The following is a description of a gene set: In this study gene expression of human blood classical monocytes (CD14++CD16-), CD16 positive monocytes (consisting of non-classical CD14+16++ and intermediate CD14++CD16+ monocytes) and CD1c+ CD19- dendritic cells from healthy subjects were investigated. species: Homo sapiens from publication Frankenberger M, Hofer TP, Marei A, Dayyani F, Schewe S, Strasser C, Aldraihim A, Stanzel F, Lang R, Hoffmann R, Prazeres da Costa O, Buch T, Ziegler-Heitbrock L (PMID 22531920) Genes down-regulated in CD16- monocytes versus dendritic cells. Human Gene Set: GSE34515_CD16_NEG_MONOCYTE_VS_DC_DN, and this is the list of marker genes: CRK, LAIR1, CDKL4, PRR5L, ADGRE5, MAP1LC3A, SEPTIN6, CSNK2B, MRPS34, BRD2, MRPL22, PRPSAP1, CREG1, ADAT1, ENPP4, CSRP3, ARMC6, RAB5C, RNF167, CPNE1, TRAPPC2L, DNMT3B, ATP8A2, PHF20, ELMOD2, GCAT, PHPT1, SERPINB8, SPPL3, EVI2B, EIF3G, RPL19, GPR108, CNR2, NEDD4L, DCAF1, IFT46, KLHL22, PI4KB, ACVR1B, SF3A3, ZNRF1, SPNS1 (SPNS lysolipid transporter 1, lysophospholipid), NSA2, RAPGEF1, NSUN2, NGDN (NCBI Gene Id 338007), STPG4, FAM219B, SLC6A6, PHB2, TTC36, GRAMD2B, RDH5, OMA1, RTCB, DHRS13, RRP15, SNAPC2, ZNF32, RAP2B, IRF2BP1, ELOVL6, SLC7A5, MRPS18B, RPAIN, PTK2B, ARFRP1, PPP5C, TNFRSF1A, CYB5B, UBASH3A, METTL22, MSN, ENTPD5, ELP1, GJA1, NDUFB2, GUSB, NOB1, SELENOS, C10orf90, SETX, PFDN5, CLIC4, IFI35, MTFR1L, GSTCD, FOXG1, PECAM1, HDAC3, DIABLO, MACROH2A1 (macroH2A.1 histone), ARHGAP45, SCNM1, CASP8, CCDC82, BSDC1 (NCBI Gene Id 55108), NTPCR, CRYL1 (NCBI Gene Id 51084), USP31, CNOT4, PPM1F, SESN3, TAF8, NSUN5, CERS6, ENPP6, UBD, SSBP4, SCAMP2, SLC29A1, HINT2, PSME1, STIM2, ARL2, BORA, EEF1AKMT1, COPZ1, RACK1, AKR7A2, RFX1, ABI3, BUD31, IFI30, ERCC5, KAT14, UGCG, IL12RB1, SNHG3, DALRD3, LAP3, CXCR6, SLC22A5, ZXDC, LIPA, BRK1, SHMT2, UBL4A, MAMDC4, SURF1, PSME3IP1, UROS, FCGR2A, QRICH1, TMCC2, MAX, CISD3, PLEKHF1, NDUFS5, YIF1B, GALNT12, WARS1, CA2, RILPL1, QTRT2, ACAA2, ORMDL1 (ORMDL sphingolipid biosynthesis regulator 1), UNC13D, UBE2L6, RSRP1, TCF25, ELOVL1, TUT1, CDKN2D, NIN, MRPL9, PARP9, CORO1C, ABCD1, TASL, STXBP1, VIPR1, POU2F2, MARCO, PREB, JCAD, STEAP2, TRIM8, ORC5, GNGT2, MON1A, B4GALNT1, CHERP, CA12, FAM174C, TMEM131, CNPPD1, IPCEF1, BSG, LPL, TEN1, DEDD, RGS19, SLC26A10P, BABAM1, MFSD3, TSC2, CDC20, HDAC10